The following is a description of a gene set: Human Gene Set: WP_ARRHYTHMOGENIC_RIGHT_VENTRICULAR_CARDIOMYOPATHY Arrhythmogenic right ventricular cardiomyopathy studied in species Homo sapiens, and this is the list of marker genes: JUP, LAMA2, SGCD, ACTN4, CACNB2, PKP2, CACNA2D1, SLC8A1, ACTG1, ACTN2, CACNA1C, TCF7L1, LEF1, CACNG7, CACNB1, TCF7L2, CACNG6, ITGA2, CACNB4, EMD, CACNB3, ITGA7, DSP, ITGB3 (integrin subunit beta 3), CACNA2D2, ITGA11, ITGB4, DSG2, CACNA1F, ACTB (actin beta), ITGB5, LMNA, ITGB6 (NCBI Gene Id 3694), GJA1, ACTN1, CACNA1S, ITGA3, RYR2, CTNNA2 (NCBI Gene Id 1496), ITGA9, ITGB1, ITGA6, CACNG8, CACNG3, ATP2A2, DMD, ITGA4, ITGA1, SGCB, ACTN3, CTNNA3, CACNG1, CDH2, SGCA, DSC2, CTNNA1, DAG1, CACNA2D3, ITGA8, CACNG5, ITGAV, CTNNB1 (NCBI Gene Id 1499), ITGA5, SGCG, CACNG2, TCF7, CACNA2D4, CACNA1D, ITGB7, CACNG4, ITGA2B, ITGB8, ITGA10, DES